The following is a description of a gene set: from publication Nakamura T, Shiojima S, Hirai Y, Iwama T, Tsuruzoe N, Hirasawa A, Katsuma S, Tsujimoto G (PMID 12646203) Genes down-regulated in mesenchymal stem cells during late phase of adipogenesis, defined as days 7 to 14 of culturing with adipogenic hormones. species: Homo sapiens Human Gene Set: NAKAMURA_ADIPOGENESIS_LATE_DN Human bone marrow mesenchymal stem cells (hMSCs) give rise to adipocytes in response to adipogenic hormones. An in-house cDNA microarray representing genes was employed to characterize the modulation of genes involved in this process. A total of genes showed temporal gene expression changes during adipogenesis, including genes encoding transcriptional regulators and signaling molecules. Semi-quantitative RT-PCR analyses confirmed differential expression at the transcriptional level of several genes identified by cDNA microarray screening. Cluster analysis of the genes regulated during the late phase (from day 7 to day 14) of hMSC adipogenesis indicated that these changes are well correlated with data previously reported for murine preadipocytes. However, during the early phase (day 1-day 5), the modulations of genes differed from those reported for the preadipocytes. These data provide novel information on the molecular mechanisms required for lineage commitment and maturation accompanying adipogenesis of hMSC., and this is the list of marker genes: POSTN, CALD1, EDIL3, ACTG2, LOX, THBS2, IER2, GDF15, TPM1, CCN1, ITGAV (NCBI Gene Id 7449), SERPINE2, HAPLN1, GLIPR1, AIMP1, COL9A3, NT5E, SMAD3, ABI3BP, CXCL12, MYH11, SRPK2 (NCBI Gene Id 6733), SLC7A5, HCK, SERPINE1, LRP3, TMEM47, ITGA3, RAI14, EPOR, ZNF133, PDE6D, TIMP3, COL15A1 (NCBI Gene Id 1306), DKK3